The following is a description of a gene set: studied in species Homo sapiens Any process that activates or increases the frequency, rate, or extent of myeloid leukocyte differentiation. Human Gene Set: GOBP_POSITIVE_REGULATION_OF_MYELOID_LEUKOCYTE_DIFFERENTIATION, and this is the list of marker genes: IL23A, PF4, RIPK1, TESC, NOTCH2, PLA2G3, NEDD9, PPARGC1B, CASP8, CSF1, TRIB1, IL5, TGFB1, LEF1, RB1, GPR68, RUNX1, IFNG, SLC9B2, TREM2, MIR486-1, ACIN1, TYROBP, EVI2B, ZFP36L1, HAX1, KLF10, CD101, TRAF6, CREB1, TNFRSF11A, POU4F2, FOS, EEIG1, CALCA, DCSTAMP, TNFSF11, TM4SF19, IL17A, ID2, MIR145, TNF, CCR1, TMEM64, PRKCA, CD4, KITLG, IL20, HCLS1, CTNNBIP1, HLA-DRB1, IL23R, HSF1 (heat shock transcription factor 1), LIF, CD74, IL12B, IL34, RPTOR, FADD, STAT5A, FES, PPP3CA, POU4F1, OCSTAMP